Given this list of marker genes TUFT1, ZNF180, SLC22A5, TUT4, SOX6, ESR1, SHISA2 (NCBI Gene Id 404758), TBL1X, GINS1, KYAT3, ZNHIT3, TSEN54, GLRX3, CYB5B, MATK (megakaryocyte-associated tyrosine kinase), RABEP1, SAPCD1, TRIM45, PSMD12, ARMCX4, PLBD2, EXO1, RAD1, NUP133, C12orf75, MLKL, SOX18, RAI1, GID4, POMGNT1, LSM4, FAM162A, OTULIN, PSIP1, PRCD, ST14, NDUFA9, MLH1, SESN3, UCK1, SAE1, GABRR1, EXD2, METTL3, B3GLCT, SMARCA5, IWS1, DUS3L, KIF3A, BRCA1, SLC30A4, TNNI3, TPRA1, BOLA2, INO80E, CENPH, DRG2, GP9, NXPE3, CNOT8, FLNB, KDM1A, MIGA1, THYN1, NSMF, TEX10, CC2D1B, IFT27, RNF150, FNBP4, SLC37A4, ATP5F1B, ZMIZ2, SLC25A13, NPRL3, PAQR8, STYX, KAT14, TTC21B, GANAB, ZSCAN22, DCAF8, TEX264, SCFD2, CEP83-DT, TMEM177, EXT1, DLG3, TUBB6, DGCR8, BUD23, MRPL36, LRRC1, NOL8 (nucleolar protein 8), TRIM27, MYEF2, TXN2, GLRX5, PLEKHA6, DIPK2A, IMMP1L, MZT2B, YWHAQ, RPS27, RPS27L, SNHG6, BHLHE40, ISLR, NUP214, BRMS1L, FPGT, PHF20, VCP, DBP, RNF220, CFAP68, RLIG1, CSTF2, ALG2, UNK, MRPL28, TAF4B, RAMP1, MRPL2, LDB1, SCAF4, ZNF623, CCT6A (chaperonin containing TCP1 subunit 6A), MAP2K5, GNAS, ZNF260, MAP1S, PSMB10 (proteasome 20S subunit beta 10), STAU2, NUDT12, MRPS25, LMF1, PAPSS1, RPS11, RAD51AP1, SETDB2, AKAP9, ZNF569, PPM1G, HMG20A, DTNBP1, IMMP2L, HAGHL, TUBGCP5, POT1, TRAPPC12, TRUB1 (TruB pseudouridine synthase family member 1), SARS1, TPI1, TIMM22, LONP1, TAP2, CSGALNACT1, CAPN2, NDUFAF5, MRPL50, JAGN1, CBX6, COX18, ZFAND1, RUSF1, RRP1, RCOR3, TMEM47, LUC7L, RPA3, ARHGAP21, USP37, ARHGAP18, FBXL17, HADHB, PTPA, HOOK1, LRFN4, FAM133B, ZC2HC1A (NCBI Gene Id 51101), P2RX4, LRP6, GSTK1, VPS50, ATP13A2, RBM14, MECR, MRPL44, RRP9, MRM1, PHETA2, RCC1L, TMEM135, RCAN3, DPP7, IFTAP, TTLL12, FPGS, MACO1, here is a description of the gene set: Genes up-regulated in comparison of LSK versus neutrophils. from publication Konuma T, Nakamura S, Miyagi S, Negishi M, Chiba T, Oguro H, Yuan J, Mochizuki-Kashio M, Ichikawa H, Miyoshi H, Vidal M, Iwama A (PMID 21540074) Human Gene Set: GSE27786_LSK_VS_NEUTROPHIL_UP Each fraction of mouse hematopoietic cells was purified by cell sorting from bone marrow of 8-week-old C57BL/6 mice, and its gene expression was analyzed. species: Homo sapiens